The following is a description of a gene set: species: Homo sapiens The process in which a relatively unspecialized cell acquires specialized features of an ameloblast, a cylindrical epithelial cell in the innermost layer of the enamel organ. Human Gene Set: GOBP_AMELOBLAST_DIFFERENTIATION, and this is the list of marker genes: ENAM, BMP7, NTF4, BMP4, TJP1, FST, PKP1, BMP2